The following is a description of a gene set: studied in species Mus musculus Mouse Gene Set: chr13A1, and this is the list of marker genes: Gm35190, Psma2, Tbce, Akr1c12, Gm10811, Gm40653, Gm7042, Gm40663, Gm40662, Gm32526, Mrpl32, Akr1e1, AW209491, 9330159N22Rik, Calml3, Gm5374, 1700016G22Rik, Gm9973, Zmynd11, Gm9616 (NCBI Gene Id 674228), Gng4, Adarb2, Pfkp, Wdr37, Gm19189, Asb13, A530058O07Rik, Gm35330, Gm8598, Gpr137b-ps, Gm25496, Gm40660, Gm7040, Gm7441, Gm20043, A530046M15Rik, Dip2c, Akr1c21, Chrm3, Gm30893, Gm2399, Edaradd, Gm46391, Gm31711, Lgals8, Gm9742, Gm25274 (predicted gene, 25274), Calm5, Gm18263, Arid4b, Gm2544, Rpl29-ps2, Gm36423, Gm9628 (predicted gene 9628), Rpl10a-ps2 (ribosomal protein L10A, pseudogene 2), Gm16419, Gm24790, Speer6-ps1 (spermatogenesis associated glutamate (E)-rich protein 6, pseudogene 1), Gm18879 (NCBI Gene Id 100417884), Gm36525, Prl2c3, Gm26129, B3galnt2, Gm30239 (predicted gene, 30239), Marcksl1-ps4, Tubal3, Gm4900, Gm10029, Larp4b, Gm31450, Ryr2, Gm8725, Gm18880, Gm19163, Gm17177, Idi1, Gm18878, Gm6562, Gm18562, Gli3, Gdi2, Gm40658, 2810429I04Rik, Gm32300, Gm7446, Gm35615, Akr1c13, Akr1c14, Gm8784, Gpr137b, Mtr, Gm7426, Calm4, Gm48329, Prl2c5, Akr1c19, Gm6556, Gm18259, Ggps1, B230303A05Rik, Gm36074, Inhba, Gm18857, Akr1c20 (aldo-keto reductase family 1, member C20), Lyst (lysosomal trafficking regulator), Gm5928, Gm46400, Ero1b, Akr1c6 (NCBI Gene Id 83702), Heatr1, Tasor2, Ucn3, Gm7046, Gm2123, 2900042G08Rik, Idi2l, Actn2, Gm2492, Zp4-ps, Idi2, Gm26861, Gm9512, Gm2423, Klf6, Gm48519, Gm5444, Net1, Gm18783, Gm10357, Gm16505, Gm36264, Gm18856, Gm18262, Gm5445, Pitrm1, Prl2c2 (NCBI Gene Id 18811), 2900024D18Rik, Akr1c18, Nid1, Gtpbp4, Gm8616, Gm5191, Gm40655, Hecw1